Given this list of marker genes Tfeb, Hes6, Rbbp7, Gmnn, Prop1, E2f5, Gtf2h2, Pou2f1, Junb, Tcf4, Pdlim1, Ptf1a, Taf5, Ascl1, Med6 (mediator complex subunit 6), Bin1, Lef1, Snapc4, Kat2a, Hdac5, Ywhab, Mnat1, Elane (NCBI Gene Id 50701), Hand2, E2f6, Scx, Lin37, Pasd1, Med29, Arnt, Rara, Neurod1, Yap1, Cebpb, Spib, Limd1, Tfe3, Rxrb, Hoxb13, Tbp, Nfya, Epas1, Bhlhe41, Anxa2, Tbx15 (T-box 15), Tle2, N4bp2l2, Rest, Gtf2a2, Taf1c, Zfp541, Mxd1, Crx, Pknox1, Smad9, Dcp1a, Nr1h5, Taf8, Bdp1, Tead4, Ccnh, Sox6, Sox15, Usf1, Twist2, Hnf4g, Batf2, Nrbf2, Dmbx1, Gatad2a, Nr1h4, Sox18, Gata4, Bex1, Dazap2, Dach1, Gtf2f2, Taf1b, Med27, Nobox, Taf4, Clock, Batf3, Foxo3, Med24, Tead3, Hdac3, Gsc, Isl1, Foxh1, Tle6, Spen, Med7 (NCBI Gene Id 66213), Elob, Mdm2 (transformed mouse 3T3 cell double minute 2), Flywch1, Gfi1b, Taf6, Med18 (NCBI Gene Id 67219), Pbx1, Pou1f1, Trp53, Gemin5 (gem nuclear organelle associated protein 5), Lhx3, Med4, Zbtb16, Atf7, Atf1, Mlx, Cdk2ap1, Pax2, Ascl3, Stat5b, Creg1, Hmga1, Ski, Bsx, Six1, Rbpj, Eny2, Stat3, Nr5a1, Hif1a, Bmal1, Aatf, Sall1, Nr4a2, Nfe2l2, Med21, Hoxc9, Gata6, Prdm10, Tfap2d, Atxn7 (NCBI Gene Id 78432), Onecut3, Med10, Bmyc, Yy1, Gata1, Otx2, Olig2, Mta2, Glis2, Tcf7l1, Mef2a, Wwtr1, Stat4, Nfyc, Jun, Arid4a, Gtf2e1, Supt3, Runx1t1, Mbd3, Runx3, Gtf3c5, Tfdp2 (NCBI Gene Id 319491), Nfe2l3, Tbx3, Pax7, Men1, Gtf2h3, Nfatc3, Hcls1, Ajuba, Tcea1, Tcf3, Yy2, Ddit3, Lin52, Taf7l, Sdr16c5, Gtf3c3, Maf, E2f8, Cdk2ap1rt, Gtf2b, Cebpg, Taf7, Fosl1, Crem, Rela, S100a10, Med1, Ncor2, Rbl2, Arid2, Snapc3, Relb, Nfe2, Pou5f1, Helt, Mxd4, Cdk4, Tfcp2, Taf2, Kat5, Nr4a1, Npas4, E2f2, Wtip, Mideas, Carm1, Ctnnbip1, Pax5 (paired box 5), Med26, Gli3, Alx4, Gcm1, Myc, Rfxap, Nkx2-1, Med22, Mkx, Deaf1, Dbp, Snai3, Med30, Nfatc4, Rbpjl (recombination signal binding protein for immunoglobulin kappa J region-like), Hoxa10, Taf9b, Cebpe, Nr1h2 (NCBI Gene Id 381996), Tbx5, Rxrg, Tead2, Mga, Per2, Hdgf, Gtf3c1, Foxd3, Nr5a2, Tbl1x, Ascc1, Stat2, Heyl, Tcf7, Stat5a, Mxd3, Ascl2, Foxe3, Phf12, Six2 (NCBI Gene Id 20472), Creb1, Sp1, Hlf, Atf4, Sfpq, Hoxa11, Ncoa2, Med23, Taf1d, Thrb, H1f0, Myocd, Pbxip1, Mafb, Rfxank (NCBI Gene Id 19727), Skor2, Atf7ip2, Meis1, Med8, E2f7, Atf5, Ercc2, Insm2 (NCBI Gene Id 56856), Taf1, Runx1, Cbfb, Xrcc6 (NCBI Gene Id 14375), Rbbp4, Med14, Cebpa, Hivep2, Thap11 (THAP domain containing 11), Pygo2, Cdk2 (NCBI Gene Id 353061), Pus1, Usp22, Hltf, Snapc1, Ctbp1, Dhrs7b, Tbpl1, Pou4f2, Ssbp3, Atxn7l3, Prdm16, Rcor1, Hdac4, Eya3, Pou2af1, Dach2, Tbx18, Cops5, Atf3, Sox5, Abt1, Creb3, Lmo2, Taf11, Six4, Lin54, Drap1, Taf6l, Nfat5, Rfx3, Ascl4, Prkdc, Tcf7l2, Runx2, Pax8, Hyal2, Ahr, Taf10, Sub1, Nfil3, Taf13 (NCBI Gene Id 99730), Ncoa3, Tada3, Tle1, Ccnd1, Rcor2, Rcor3, Nkx2-5, Hdac2, Akirin2, Med20, Hmgb1, Adnp, Pitx2, Sox4, Cdk7, Cebpz, Tcf15, Batf, Mta1, Tcf12, Gfi1, Pax1, Zfp42, Arid5a, E2f1, Tfap2a, Nr4a3, Nr1i2, Olig1 (NCBI Gene Id 50914), Stat6, Klf5, Sall4 (spalt like transcription factor 4), Gtf2h4, Hnrnpu, Cry2, Tle7, Pou2f3, Sox9, Alx1, Ldb2, Parp1, Rxra, Pbx3, Gtf3c6, Skor1, Apex1, Gtf3c4, Hax1, Med15, Gtf2e2, Gtf3c2, Nfatc1, Nfyb (NCBI Gene Id 18045), Sox14, Smad3 (SMAD family member 3), Etv3, Bex2, Wwox, Ets1, Rfx5, Sin3a, Lin9, Nono (NCBI Gene Id 99469), Cdx2, Ldb1, Insm1, Taf4b, Stat1, Xbp1, Mef2b, Mafg, Lbx1, Myod1, Smad5, Hey2, Brf2, Smad1, Foxa2, Rbbp8, Nr6a1, Hipk2 (homeodomain interacting protein kinase 2), Hdac1, Skil, Coro2a (coronin, actin binding protein 2A), Satb2, Cbx5, Taf3, Ddx20, Maff, Trim28, Bach1 (NCBI Gene Id 76136), Taf1a, Ncoa1, Gtf2h5, Ctnnb1, Cebpd, Hand1, Smad6, Ncoa6, Nr2e3, Bach2, Jdp2, Msx2, Hoxa9, Ercc3, Trrap, Tal1 (NCBI Gene Id 21349), Gps2 (G protein pathway suppressor 2), Ing2, Nrf1, Zfpm1, Esr1, Fosl2, Sry, Pou4f1, Irf9, Mta3, Foxf2, Med19, Sox17, Bmal2, Rb1, Rarg, Gata2, Ankrd1, Smad2, E2f3, Klf4, Tle3, Psmc5 (protease (prosome, macropain) 26S subunit, ATPase 5), Ikzf1, Brf1, Cbx3, Hoxb9, Tle4, Mbd2, Bcl9, Tfcp2l1, Taf9, Riox2, Irx4, Arnt2, Pbx2, Hoxd12, C1d, Six6, Med17, Tcf21, Med31, Pitx1, Max, Lmo4, Pax4, Sox2, Pax9, Ncor1, Nfkb1, Tead1, Atf6, Hnrnpab, Atf1-ps, Thra, Rbm14, E2f4, Gtf2a1l, Med25, Bcl9l, Pou4f3, Tfdp1, Msx1, Gatad2b, Mier1, Npas2, Pou3f2, Gtf2h1, Lpin1, Chd3, Ecsit, Tbx2, Med11, Taf5l, Nr1h3, Myb, Ascl5, Med16, Naa15, Six3, Crebbp, Atf2, Fos, Lhx1, Pax6, Mlxip, Nfatc2, Jazf1, Atf6b, Dr1, Med28, Barx2, Gtf2a1, Crebzf, Chd5, Zfhx3, Gtf2f1, Mlxipl, Mdm4, Hnf1b, Sox8, Smad7, Pou3f1, Ptov1, Jund, Vdr, Pax3, Med9, Sap18, Hnf1a, Rbl1, Sp3, Cdk2ap2, Mxi1, Ctbp2, Trerf1, Depdc1a, Smad4, Chd4, Taf12, Spi1, Zfp143, Hdac9, Snf8, Figla, Six5, Atf7ip, Pparg, Ep300, Tbl1xr1, here is a description of the gene set: A protein complex that is capable of associating with DNA by direct binding, or via other DNA-binding proteins or complexes, and regulating transcription. Mouse Gene Set: GOCC_TRANSCRIPTION_REGULATOR_COMPLEX species: Mus musculus